The following is a description of a gene set: species: Homo sapiens Human Gene Set: GOBP_MYELOID_DENDRITIC_CELL_CYTOKINE_PRODUCTION Any process that contributes to cytokine production by a myeloid dendritic cell., and this is the list of marker genes: MAVS, TICAM1, CAMK4, RIGI, DDX1, DHX36, DDX21